The following is a description of a gene set: A transition where a mesenchymal cell establishes apical/basolateral polarity,forms intercellular adhesive junctions, synthesizes basement membrane components and becomes an epithelial cell that will contribute to the shaping of the metanephros. studied in species Mus musculus Mouse Gene Set: GOBP_MESENCHYMAL_TO_EPITHELIAL_TRANSITION_INVOLVED_IN_METANEPHROS_MORPHOGENESIS, and this is the list of marker genes: Six2, Ctnnb1, Pax8, Stat1, Cited1, Sall1, Wnt9b, Gdnf, Lif, Pax2, Smo, Grem1